Given this list of marker genes Gng4, Gnaq (guanine nucleotide binding protein, alpha q polypeptide), Gnb1, P2ry1, Gng5, Pla2g4a, Gngt1, Gnb3, Gng2, Gng3, Gna11, Gng13, Gng12, Gnb5, Gna15, Gnb2, Src, Gng11, Mapk14, Gng10, Gng8, Gnb4, Gna14, Gng7, Gngt2, here is a description of the gene set: ADP signalling through P2Y purinoceptor 1 species: Mus musculus Mouse Gene Set: REACTOME_ADP_SIGNALLING_THROUGH_P2Y_PURINOCEPTOR_1